Given this list of marker genes NPRL3 (NCBI Gene Id 8131), LRP1 (LDL receptor related protein 1), MIR205, MIR145, EYA1, PDGFRB, FGF8, CHD7, EFNB2, SOX4 (SRY-box transcription factor 4), SIX1, EFEMP2, BMPR1A, RBPJ, NOTCH1 (notch receptor 1), TBX2, SRF, JAG1 (NCBI Gene Id 3715), TFAP2B, MYLK, TBX1, NAGLU, SEC24B, MIR143, PROX1, DLL4, TGFBR2, HEY2, FKBP10, FOXH1, ENG, HES1, MIR29B1, HEY1, ACVRL1, ADAMTS9, COL3A1, TGFB2, here is a description of the gene set: Human Gene Set: GOBP_AORTA_MORPHOGENESIS The process in which the anatomical structures of an aorta are generated and organized. An aorta is an artery that carries blood from the heart to other parts of the body. species: Homo sapiens